Given this list of marker genes Apoh, Slamf8, Ins2, Grn, Noxa1, Insr, Ncf1, Ins1, Lbp, Rac1, Bcr, Camk1d, Clec7a (C-type lectin domain family 7, member a), Jchain, Rac2, Dusp10, Rps19, S100a9, here is a description of the gene set: Mouse Gene Set: GOBP_REGULATION_OF_RESPIRATORY_BURST studied in species Mus musculus Any process that modulates the rate frequency or extent of a phase of elevated metabolic activity, during which oxygen consumption increases; this leads to the production, by an NADH dependent system, of hydrogen peroxide (H2O2), superoxide anions and hydroxyl radicals.